The following is a description of a gene set: studied in species Homo sapiens Human Gene Set: LAKE_ADULT_KIDNEY_C7_PROXIMAL_TUBULE_EPITHELIAL_CELLS_S3 from publication Lake BB, Chen S, Hoshi M, Plongthongkum N, Salamon D, Knoten A, Vijayan A, Venkatesh R, Kim EH, Gao D, Gaut J, Zhang K, Jain S (PMID 31249312), and this is the list of marker genes: BNC2, SDK1, RPS21, PABPC1, EEF1A1, S100A6, SDC4, RPLP1, RPS25, HSPA5, LRP2 (LDL receptor related protein 2), NUCKS1, RPL7A, RPL19, PSAP, DCDC2, RPS14, AGBL4, RPL34, MT2A, LAPTM4A (lysosomal protein transmembrane 4 alpha), SPATS2L, EEF2, RPS20, CALM1, MT1G, CD63, GALNT14, HSP90AB1, CDH6, SIPA1L1, HINT1, PPFIBP1, RPL23, PTMA, RPL35, RPL31, SLC13A1, AKAP12, RPS6, SLC17A1, RPS17, RPL21, RPL6 (NCBI Gene Id 6128), RPS8, SLC16A12, TPM1, CALD1, RPS7, RPS23, GPX3, TMSB10, RPL4, RPL37A, COX4I1, RPLP2, RPS28, RPL38, COL18A1, RPL27A, RPL12, RPS3A, SERF2, PDZK1IP1, PTPRD, RPL13, RPL14, HLA-A, NFIA, RPS24, RPL5, RHEX, RPS15, RPL35A, RPS11, MTATP6P1, DLGAP1, RPL27, PICALM, KLF6, NPM1, COL4A2 (collagen type IV alpha 2 chain), NCL, CNKSR3, RPS13, RPS19, RPL9, ARID5B, FTL, C11orf54, ZBTB38, FTH1, UGT2B7, TTC28, RPL24, RPL32, HSPD1, RPS27A, RPL7, RPSA, RPL11, ITGB8, RPS18, ANPEP, ALDOB, RPS9, KCNJ15, COX7C, CXCL14, NOX4, RERG, AQP1, RPL3, CNDP2, PARD3, RPL37, EZR, BCL2, RPS16, RPL8, RPS4X, RETREG1, CTSB, ATP5F1E (NCBI Gene Id 514), RPL13A, WWC1, RPL18, RPS12, GATM, PEBP1, NUMB, ITGAV, MT1E, CCNI, TPT1